Given this list of marker genes Hsf1, Fkbp4, Hsbp1, Ep300, Hspa1l (NCBI Gene Id 15482), Dnajb1, Hspa2, here is a description of the gene set: part of: HSF1-dependent transactivation Reactome Pathway: Attenuation phase This event has been computationally inferred from an event that has been demonstrated in another species.<p>The inference is based on the homology mapping from PANTHER. Briefly, reactions for which all involved PhysicalEntities (in input, output and catalyst) have a mapped orthologue/paralogue (for complexes at least 75% of components must have a mapping) are inferred to the other species. species: Mus musculus electronically inferred by orthology from the curated human pathway